Given this list of marker genes FBXW5, ALOX12 (arachidonate 12-lipoxygenase, 12S type), TXNDC11, ITGB3, LRRC74A, CHRNG, LDB1, SLC7A1, PLK1, NINL, CARF, CTTNBP2, CDC42BPG, AGAP3, C19orf53, SLC29A2, REG4, ZBTB45, UQCRB, POC1A, SAG, NKX2-1, LIPG, SLC15A4, NF1, TBCA, ACTR1A, ITSN1, CFAP70, AKT2, KLC1, HAPSTR1, LCOR, AMER3, ARAF, PSTPIP2, SNX15 (sorting nexin 15), ALG1, LAMA2, SRPRB, CCDC85B, NDUFB4, ETHE1, NDUFAF2, COMMD9, TFAP4, C2orf76, TAB1, NDUFA6, RC3H1, FAM120A, SPSB2, NEU1, CUBN, HYCC2, TMED9, UBE2M, PYGO2, MPDU1, DCAF8, FKBP2, MORN5, UNC13C, CYLC2, CHCHD2, TXN2, WBP11, TMEM150C, MRPL4, PRR11, SETD1B, TNFRSF25, FAR1, ALDH9A1 (aldehyde dehydrogenase 9 family member A1), R3HDM4, AMH, C1orf122, GLYR1, RUSC2, CXCL6, TSPAN15 (NCBI Gene Id 23555), ACTL10, KCTD20, RPS26, TGIF2LX, FBXO31, CUTA, G6PC3, NOL10, ARF5, SLC10A3, PTDSS1, AKT1S1, CKS1B, NAA40, KCNE3, ORAI3, SMTNL1 (smoothelin like 1), UBXN1 (NCBI Gene Id 92151), IL17B, CIAPIN1, ESRRA, GNB2, VCPIP1, REX1BD, ARRDC5, FOXK2, ATP6V0A1, EIF4G1 (eukaryotic translation initiation factor 4 gamma 1), UHRF1, GK, PPBP, P3H1, BCL7B, RNF19B, LCORL, NLE1, RAB30, PLCB1, NTN3, ATP6AP2, DEDD, WIZ, PGAM2 (NCBI Gene Id 5224), BUD23, DSP, SLC5A6, LMAN2, LRP8, RBM7, SAMM50, DCBLD1, FTL, PLAGL2, ASZ1, ERI3, THOP1, CNFN (cornifelin), BCAP31, ZMAT2, FOXD4L1, FHIP2B, SERPINE2, MYDGF, YKT6, F10, TMEM101, RUSF1, RPS6KB2, PPHLN1, PRDX5, SLC25A22, PLEKHJ1, SVIP, NT5C, IL31RA, IER3IP1, NDUFS5, FGB, NDUFC1, LAMP1, TRAPPC2L, NCAPG, TMX1, GSTCD, C6orf118, TOMM7, CTSB, ICAM5, IDO1, DGKQ, KDM8, TOMM40L, EIF2AK1, IFI30, ATG9B, WASF3, SARS2, TMPRSS11E, CDK10, PPP1R35, UBL5, WNT8A, FHAD1, RPLP2, TELO2, C1orf159 (NCBI Gene Id 54991), NCLN, SUZ12, SMIM12, SMIM11, ATP5MG, SIGMAR1, FBXO34, SLC35F6, ERCC6L, MDM1 (Mdm1 nuclear protein), PPIF, KCNJ4, PRM2, here is a description of the gene set: from publication Yusuf I, Kageyama R, Monticelli L, Johnston RJ, Ditoro D, Hansen K, Barnett B, Crotty S (PMID 20525889) Genes down-regulated in CD4 Tfh (T follicular helper) cells: Tfh versus Tfh from germinal center. Human Gene Set: GSE21380_TFH_VS_GERMINAL_CENTER_TFH_CD4_TCELL_DN CD4 T cell help is critical for both the generation and maintenance of germinal centers, and T follicular helper (TFH) cells are the CD4 T cell subset required for this process. SAP (SH2D1A) expression in CD4 T cells is essential for germinal center development. However, SAP-deficient mice have only a moderate defect in TFH differentiation as defined by common TFH surface markers. CXCR5+ TFH cells are found within the germinal center as well as along the boundary regions of T/B cell zones. Here we show that germinal center associated T cells (GC TFH) can be identified by their co-expression of CXCR5 and the GL7 epitope, allowing for phenotypic and functional analysis of TFH and GC TFH populations. Here we show GC TFH are a functionally discrete subset of further polarized TFH cells, with enhanced B cell help capacity and a specialized ability to produce IL-4 in a TH2-independent manner. Strikingly, SAP-deficient mice have an absence of the GC TFH subset and SAP- TFH are defective in IL-4 and IL-21 production. We further demonstrate that SLAM (Slamf1, CD150), a surface receptor that utilizes SAP signaling, is specifically required for IL-4 production by GC TFH. GC TFH cells require IL-4 and IL-21 production for optimal help to B cells. These data illustrate complexities of SAP-dependent SLAM family receptor signaling, revealing a prominent role for SLAM receptor ligation in IL-4 production by germinal center CD4 T cells but not in TFH and GC TFH differentiation. studied in species Homo sapiens